Given this list of marker genes CRTC2, RASSF1, IGF1R, SMAD7, DLK1, MYC, AKT1, BRAF, FOXM1, RAB43, INSR, CDK4, PGF, IGF1, INS, FLT1, MAPK1, AKT2, TGFBR1, PDGFA, PDX1, FOXO1 (NCBI Gene Id 2308), KRAS, AKT3, MAPK3, CDK2, here is a description of the gene set: studied in species Homo sapiens Human Gene Set: WP_GROWTH_FACTORS_AND_HORMONES_IN_BETA_CELL_PROLIFERATION Growth factors and hormones in beta cell proliferation